Given this list of marker genes Psmc4, Psma1, Ubb, Psmd6, Psmd1, Nfkbie, Psma6, Rps27a, Psmc6, Psmd12, Psmc3, Psma7, Psmc2, Psma4, Psma3, Psma5, Psmb4, Nfkbib, Psmb7, Psmb6, Psmc5, Rela, Psmd7, Psmc1, Cul1, Nfkbia, Psma2, Psmd13, Malt1, Ikbkb (inhibitor of kappaB kinase beta), Psmb5, Nfkb1, here is a description of the gene set: electronically inferred by orthology from the curated human pathway This event has been computationally inferred from an event that has been demonstrated in another species.<p>The inference is based on the homology mapping from PANTHER. Briefly, reactions for which all involved PhysicalEntities (in input, output and catalyst) have a mapped orthologue/paralogue (for complexes at least 75% of components must have a mapping) are inferred to the other species. Reactome Pathway: Activation of NF-kappaB in B cells part of: Downstream signaling events of B Cell Receptor (BCR) species: Mus musculus